The following is a description of a gene set: Human Gene Set: GOMF_OXIDOREDUCTASE_ACTIVITY_ACTING_ON_METAL_IONS_NAD_OR_NADP_AS_ACCEPTOR species: Homo sapiens Catalysis of an oxidation-reduction in which the metal ion is reduced and NAD+ or NADP+ acts as an electron acceptor., and this is the list of marker genes: MMACHC, STEAP1, MTRR, STEAP3, STEAP4, STEAP2